Given this list of marker genes OPHN1, SCRIB, CARMIL2, CAMSAP3, GBF1, MSN, SYNE4, WNT5A, LAMA1, MAP1B, FSCN1, PTK7, SH3BP1, PATJ, EZR, PRKCI, MYO9A, CDC42, FOXJ1, FAT1, FOXF1, TCF15, RHOA, TTC8, IFT20, NHERF1, RAP2A, here is a description of the gene set: species: Homo sapiens Any cellular process that results in the specification, formation or maintenance of monopolar intracellular organization or cell growth patterns. Monopolar cell organization is directional organization along an axis. Human Gene Set: GOBP_ESTABLISHMENT_OR_MAINTENANCE_OF_MONOPOLAR_CELL_POLARITY